The following is a description of a gene set: The directed movement of substances from the endoplasmic reticulum (ER) to the Golgi, mediated by COP II vesicles. Small COP II coated vesicles form from the ER and then fuse directly with the cis-Golgi. Larger structures are transported along microtubules to the cis-Golgi. species: Homo sapiens Human Gene Set: GOBP_ENDOPLASMIC_RETICULUM_TO_GOLGI_VESICLE_MEDIATED_TRANSPORT, and this is the list of marker genes: PEF1, LMAN1, STEEP1, PGAP1, RABGGTA, TMED6, ERGIC3, TEX261, BET1, LMF1, RAB1B, TRAPPC4, RINT1, VAPA, ERGIC2, GOSR1, RNF139, SCAP, SEC13, ARF4, TMED2, COG3, TRAPPC1, PPP6C, CTAGE9, PDCD6, SORL1, GOPC, USE1, COPG2, LMAN2, RAB29, SEC23IP, CTAGE1, CREB3L2, YKT6 (YKT6 v-SNARE homolog), PREB (NCBI Gene Id 115725), MPPE1, GOLT1B, ARCN1, SAR1B, WHAMM (NCBI Gene Id 123720), TRAPPC12 (trafficking protein particle complex subunit 12), COPG1, KLHL12, RAB2A, TMED10, ERO1B, STX5, STX17, BCAP29, COPB1, GAS1, YIF1A, TRAPPC11, CUL3, GOLT1A, VTI1A, SEC24C, TRAPPC3L, TRAPPC2, YIF1B, SCFD1, SEC22A, ZW10, VAPB, ATL3, SEC24B, SEC16A, TRAPPC10, TRAPPC8, TMED7, SEC16B, STX18, TRAPPC9, SEC24A, COPB2, IER3IP1, HYOU1, TRAPPC6B, TMED3, CTAGE6, MAPK15, LMAN1L, MIA3 (NCBI Gene Id 440718), CTAGE4, TFG, TMED1, LMAN2L, ERGIC1, TRAPPC13, RABGGTB, TMED5, TRIP11, SEC23B, RAB1A, LRRK2, P4HB (NCBI Gene Id 94756), SEC22B, ANK1, SEC22C, VCP, INSIG1, SPAST (spastin), TRAPPC6A, CIDEB, SEC24D, TMED4, USO1, COPA (NCBI Gene Id 1314), MIA2, TBC1D20, YIPF5, CSNK1D, SURF4 (surfeit 4), NRBP1, GOLGA2 (golgin A2), VAMP7, TRAPPC5, CNIH4, TRAPPC3, GOSR2, GBF1, YIPF4, CTAGE15, CTAGE8, ATL2, TMED9, COPE, SEC31B, TRAPPC2L, SEC23A, BCAP31, YIPF6, SEC31A, RANGRF, CRYZL2P-SEC16B, YIPF7, SAR1A (NCBI Gene Id 56909), TRAPPC2B